Given this list of marker genes GRIK1, GRIK3 (NCBI Gene Id 2899), GRIK2, GRIK4, GRIK5, here is a description of the gene set: species: Homo sapiens An assembly of four or five subunits which form a structure with an extracellular N-terminus and a large loop that together form the ligand binding domain. The C-terminus is intracellular. The ionotropic glutamate receptor complex itself acts as a ligand gated ion channel; on binding glutamate, charged ions pass through a channel in the center of the receptor complex. Kainate receptors are multimeric assemblies of GluK1-3 (also called GluR5-7), GluK4 (KA1) and GluK5 (KA2) subunits. Human Gene Set: GOCC_KAINATE_SELECTIVE_GLUTAMATE_RECEPTOR_COMPLEX